The following is a description of a gene set: Human Gene Set: HP_LONG_THORAX Increased inferior to superior extent of the thorax. species: Homo sapiens Long thorax, and this is the list of marker genes: KAT6A (NCBI Gene Id 7994), PRKACB, PRKACA, NAA10, TRPV4, INTU, PCGF2, BCOR